The following is a description of a gene set: Mouse Gene Set: MIR_452_5P from publication Chen Y, Wang X (PMID 31504780) Genes predicted to be targets of miRBase v22 microRNA mmu_miR_452_5p in miRDB v6.0 with MirTarget v4 prediction scores > 80 (high confidence targets). species: Mus musculus, and this is the list of marker genes: Kcnip4, Dock9, Gria3, Cfap43, Fdx1, Arhgap25, Rnf224, Unkl, Ero1a, Rai14, Sdc2, Tox, Ppp2r5e, 2700097O09Rik, Lhx9, C1qtnf7, Ank3, Glud1, Prn, Phf6, Hif3a, Defb3, Doc2a, Trps1, Abhd16b, Stxbp5, Ephb1, Mybpc1, Wdr26 (NCBI Gene Id 98607), Uhmk1, Gphb5, Nkain2, Ankrd52, Atl1, Slain2, Chm, Krt33b, Tspyl4, Kcnd3, Cacnb2, Sav1, Rps6kb1, Col9a3, Unc5a, Kcnmb2, Fbxo32, Atp2c1 (NCBI Gene Id 76638, ATPase, Ca++-sequestering), Mab21l1, Bnc2, Vmn1r235, Gns, Frrs1l, Ttll7, Fubp1 (NCBI Gene Id 77392), Sp3, Nr4a3, Tax1bp1, Tmem71, Nabp1, Tmem47, Magt1, Aak1, Gnaz, Ccpg1, Abhd10, Nkx2-2, Dyrk3, Zfp473, Msi2, Zswim5, Kctd5, Cfap97, Slc30a4, Gsk3b, Vcf2, Ccn1, Riok1, Slc13a1, Sall1, Sfrp2 (secreted frizzled-related protein 2), Zic1, Xdh (NCBI Gene Id 22436), Cd99l2, Bicdl2, Gpr83 (NCBI Gene Id 14608), Nup160, Lingo2, Sar1b, Chek1, Tcp11l2, Wdr45b, Prnd, Epyc, Shank2, Lce1b, Nin, Adcyap1, Ceacam10, Lrp8, Zfp938, Trim67, Pcnx1, 1700017N19Rik, Cdh12, Cpeb4, Ate1, Elovl7, Masp1, Gatm, Hspa4 (NCBI Gene Id 15525), Man1c1, Sel1l, Xpnpep1, Dixdc1, Zfp850, Pcdh8, P2ry4, Mc2r, Tbx20, Khdc3, Phf20, Ube2a, Leng8, Sco1, Slc7a1, Cox7a2l, Prune1, Rbbp6, Rell1, Tshz3, Itsn2, Rab6a, Reep1, Slc6a8, Nhsl2, Syn3, Apaf1, Ubr5